Given this list of marker genes P2RX7, METAP1, FBXO30, LAMTOR3, CDYL, SLC39A6, TSR1, SNHG17, MTAP, HMGXB3, NIP7, ISG20L2, PUS7, ATF3, NOL9, OSM, IL24 (NCBI Gene Id 11009), PANK3, EXOC5, RRP1B, IFRD2, AHCYL2, GNAQ, FBXO17, ATAD3A, THUMPD1, DDX54, SLC37A3, WDR77, ZMYND19, NEDD1, BTG3, HSPA4, DGKE, PCGF6, AGPAT3 (1-acylglycerol-3-phosphate O-acyltransferase 3), FAM118B, ZNF263, CMTM6, PPP2R1B, HEMK1, DIMT1, NDUFAF4, BCL2L1, KCNK5, TIMM8A, LRATD2, ZNF507, MAP3K8, SRM, SPRED1, C3orf18, TAFA3, DPH5, HSD17B7, AFG2B, LRP8, JAGN1, POLR3D, DCUN1D3, UTP15, RIOX1, LIG3, FPGS, IL2RA, SPRY1, TUBA4A, F2R, TNF, SLC25A33 (NCBI Gene Id 84275), SLC25A32, MGAT2, YRDC, GADD45G, NAF1, MPHOSPH10, NOP2, TMEM185A, ARID5A, SEPTIN9, ARL4A, NOC2L, ITIH5, TWNK, NOC4L, PRICKLE1, UTP18, RCN1, AEN, PER2, ENTR1, CISH, WDR3, DCAF13, CDK6, IL13, AQP9, SOCS1, GRWD1, CTU2, SHMT1, SLC4A7, PDP2, KTI12, CSRNP1, AFG2A, PTGER4 (NCBI Gene Id 5734), CLPX, UTP25, IRF4 (NCBI Gene Id 4592), LTA, EXOSC1, CLINT1, CD48, NOB1, PPAN, LIF, WDR75, CCDC86, RRS1, CTPS1, ZBTB11, CNDP2, GNL2, ALKBH1, CORO2A, KANSL2, NLE1, ITK, BBS12, SURF6, UTP4 (NCBI Gene Id 84916), CEBPZ, SOCS2, SEC24A (NCBI Gene Id 10802), IFNG, POLR1B, RGS1, POLR3E, THUMPD3, LARS1, IL4R, CASP8, USPL1, TAMALIN, TBRG4, PIM1, MYC, DEGS1, PTGER2, TEX2, SELENOS, MAT2A, SLC7A1, LARP4, TXNRD1, BAZ1A, CDKN1A, TAF4B, GMPPB, FRMD6, TIMM10, MAK16, RASA2, ABHD17B, DHX33, SYPL1, LARP1, GEMIN4, KRR1, USP10, RNF19B, RPP14, YAE1, GNL3, SLC14A1, KRI1, BYSL, BAG5, NOLC1, HBEGF, LYPLA2, NIFK, RPF2 (ribosome production factor 2 homolog), ZNF608, FKBP1A, EIF1AY, GPR83, HK2, EEF1E1, QSOX2, WDR43, CHCHD4, TMEM158, MFSD2A, PGLYRP2, BDP1, NHERF1, PRMT6, here is a description of the gene set: from publication Busconi L, Bauer JW, Tumang JR, Laws A, Perkins-Mesires K, Tabor AS, Lau C, Corley RB, Rothstein TL, Lund FE, Behrens TW, Marshak-Rothstein A (PMID 18025183) We have previously shown that rheumatoid factors (RF) produced by Fas-deficient autoimmune-prone mice typically bind autologous IgG2a with remarkably low affinity. Nevertheless, B cells representative of this RF population proliferate vigorously in response IgG2a/chromatin immune complexes through a mechanism dependent on the sequential engagement of the BCR and Toll-like receptor 9 (TLR9). To more precisely address the role of both receptors in this response, we analyzed the signaling pathways activated in AM14 B cells stimulated with these complexes. We found that the BCR not only serves to direct the chromatin complex to an internal compartment where it can engage TLR9 but also transmits a suboptimal signal that in combination with the signals emanating from TLR9 leads to NF-kappa-B activation and proliferation. Importantly, engagement of both receptors leads to the upregulation of a group of gene products, not induced by the BCR or TLR9 alone, that include IL-2. These data indicate that autoreactive B cells, stimulated by a combination of BCR and TLR9 ligands, acquire functional properties that may contribute to the activation of additional cells involved in the autoimmune disease process. Human Gene Set: GSE6674_ANTI_IGM_VS_CPG_STIM_BCELL_DN Genes down-regulated in B lymphocytes: anti IgM versus CpG oligodeoxynucleotide 1826. studied in species Homo sapiens